Given this list of marker genes STAT4, ICAM1, CD4, RELB, NFKB2, CCL20, IL1RN, PLAUR, CYP1B1, MAP3K8, PDE4B, CD80, HLA-DQA1, CD9, CXCL2, TNFAIP6, HLA-DMA, CCL4, CD83, CCL5, SERPINB9, HLA-B, IL4I1, IL1B, IL23A, PCTP, BCL3, here is a description of the gene set: Human Gene Set: LI_PBMC_MENACTRA_AGE_18_45YO_CORRELATED_WITH_ANTI_DT_ANTIBODY_3DY_NEGATIVE studied in species Homo sapiens from publication Li S, Rouphael N, Duraisingham S, Romero-Steiner S, Presnell S, Davis C, Schmidt DS, Johnson SE, Milton A, Rajam G, Kasturi S, Carlone GM, Quinn C, Chaussabel D, Palucka AK, Mulligan MJ, Ahmed R, Stephens DS, Nakaya HI, Pulendran B (PMID 24336226) Genes negatively correlated with antibody response in peripheral blood mononuclear cell in adults (18-45) (anti-DT antibody-correlation profile) after exposure to Menactra, time point 3D Many vaccines induce protective immunity via antibodies. Systems biology approaches have been used to determine signatures that can be used to predict vaccine-induced immunity in humans, but whether there is a 'universal signature' that can be used to predict antibody responses to any vaccine is unknown. Here we did systems analyses of immune responses to the polysaccharide and conjugate vaccines against meningococcus in healthy adults, in the broader context of published studies of vaccines against yellow fever virus and influenza virus. To achieve this, we did a large-scale network integration of publicly available human blood transcriptomes and systems-scale databases in specific biological contexts and deduced a set of transcription modules in blood. Those modules revealed distinct transcriptional signatures of antibody responses to different classes of vaccines, which provided key insights into primary viral, protein recall and anti-polysaccharide responses. Our results elucidate the early transcriptional programs that orchestrate vaccine immunity in humans and demonstrate the power of integrative network modeling.